Given this list of marker genes Nkx2-5, Prickle1, Tgfb2, Tbx5, Dhx36 (DEAH-box helicase 36), here is a description of the gene set: Mouse Gene Set: GOBP_REGULATION_OF_CARDIOBLAST_DIFFERENTIATION Any process that modulates the frequency, rate or extent of cardioblast differentiation, the process in which a relatively unspecialized mesodermal cell acquires the specialized structural and/or functional features of a cardioblast. A cardioblast is a cardiac precursor cell. It is a cell that has been committed to a cardiac fate, but will undergo more cell division rather than terminally differentiating. studied in species Mus musculus